The following is a description of a gene set: species: Homo sapiens Human Gene Set: GOMF_INOSITOL_TRISPHOSPHATE_KINASE_ACTIVITY Catalysis of the reaction: inositol trisphosphate + ATP = inositol tetrakisphosphate + ADP + H+., and this is the list of marker genes: IPMK, ITPK1, ITPKA, ITPKC, ITPKB